The following is a description of a gene set: Bicarbonate transporters species: Homo sapiens Human Gene Set: REACTOME_BICARBONATE_TRANSPORTERS, and this is the list of marker genes: SLC4A3, SLC4A1, SLC4A10, SLC4A5, SLC4A9, SLC4A7, SLC4A4, SLC4A2, SLC4A8, AHCYL2